Given this list of marker genes RPIA, here is a description of the gene set: A mutation in ribose-5-phosphate isomerase (RPIA), an enzyme of the pentose phosphate pathway that normally mediates the reversible interconversion of D-ribulose 5-phosphate and ribose 5-phosphate, has been associated with a slowly progressive leukoencephalopathy. species: Homo sapiens Reactome Pathway: RPIA deficiency: failed conversion of RU5P to R5P part of: Pentose phosphate pathway disease